Given this list of marker genes PTGS2, TMEM176A, AP3S1, CCN5, TMEM176B, EMB, DDR1, CDO1, FGFR2, IL11RA, CRTAP, PTX3, BTG3, LXN, CXCL12, MAGED1, ZFP36 (NCBI Gene Id 7538), VEGFD, NSG1, FOXP1, PROS1, RNASE4, IGSF10, DPEP1, LTBP2, MAN2A1, SLC12A2, STAT3 (signal transducer and activator of transcription 3), LOXL1, CEBPB, CCDC80, TNC, IL1RL1, LAMA4, C3, CXCL6, SLPI, MGP, OSMR, EIF2AK4, PDK4, LOX, FOS, ADAM23, VCAM1, CYP1B1, ZFP36L2, IL1R1, VDR, FAS, MEG3, NID1, here is a description of the gene set: Mutational activation of ras genes is required for the onset and maintenance of different malignancies. Here we show, using a combination of molecular physiology, nutritional perturbations and transcriptional profiling, that full penetrance of phenotypes related to oncogenic Ras activation, including the shift of carbon metabolism towards fermentation and upregulation of key cell cycle regulators, is dependent upon glucose availability. These responses are induced by Ras activation, being specifically reverted by downregulation of the Ras pathway obtained through the expression of a dominant-negative Ras-specific guanine nucleotide exchange protein. Our data allow to link directly to ras activation the alteration in energy metabolism of cancer cells, their fragility towards glucose shortage and ensuing apoptotic death. Human Gene Set: CHIARADONNA_NEOPLASTIC_TRANSFORMATION_KRAS_CDC25_DN from publication Chiaradonna F, Sacco E, Manzoni R, Giorgio M, Vanoni M, Alberghina L (PMID 16607279) Genes down-regulated in NIH3T3 cells (fibroblasts) transformed by activated KRAS vs those reverted to normal cells upon over-expression of a dominant negative form of CDC25. species: Mus musculus